Given this list of marker genes Ciz1, Rbm4, Cdk3, Cdk2, Cdk14, Crabp2, Rack1, Mdfic, Inca1, Cdk13, Cdkn1b, Hdac3, Gak, Proca1, Fbxo31, Cdk6, Xrcc6, Cdk5rap3, Ptch1 (NCBI Gene Id 77214), Cdk12, Cdkn1a, Ube3d, Gps2, Cdk4, Klhdc9, Insm1, Cul3, Tnfaip1, Poln, Cdk1, Usp2, Cdk15, Herc6, Ndc80, Fbxw7, here is a description of the gene set: species: Mus musculus Binding to cyclins, proteins whose levels in a cell varies markedly during the cell cycle, rising steadily until mitosis, then falling abruptly to zero. As cyclins reach a threshold level, they are thought to drive cells into G2 phase and thus to mitosis. Mouse Gene Set: GOMF_CYCLIN_BINDING